Given this list of marker genes Ndc1, Nup93, Hk2, Gnpda1, Aldob, G6pc2, Eno4, Nup205, G6pc3, Nup133 (nucleoporin 133), Nup155, Eno3, Nup42, Gckr, Pfkl, Fbp2, Nup58, Pgam2, Slc37a4, Pgk2, Aaas, Slc37a1, Nup54, Nup210, Nup85, Gapdhs, Aldoa, Pfkfb1, Seh1l, Tpi1, G6pc1, Pkm, Slc37a2, Pgm2l1, Rae1, Pck2, Hkdc1, Hk3, here is a description of the gene set: This event has been computationally inferred from an event that has been demonstrated in another species.<p>The inference is based on the homology mapping from PANTHER. Briefly, reactions for which all involved PhysicalEntities (in input, output and catalyst) have a mapped orthologue/paralogue (for complexes at least 75% of components must have a mapping) are inferred to the other species. part of: Metabolism of carbohydrates and carbohydrate derivatives Reactome Pathway: Glucose metabolism electronically inferred by orthology from the curated human pathway studied in species Mus musculus